The following is a description of a gene set: Mouse Gene Set: GOBP_SECONDARY_METABOLIC_PROCESS studied in species Mus musculus The chemical reactions and pathways resulting in many of the chemical changes of compounds that are not necessarily required for growth and maintenance of cells, and are often unique to a taxon. In multicellular organisms secondary metabolism is generally carried out in specific cell types, and may be useful for the organism as a whole. In unicellular organisms, secondary metabolism is often used for the production of antibiotics or for the utilization and acquisition of unusual nutrients., and this is the list of marker genes: Tyrp1, Cyp2a12, Mc1r (NCBI Gene Id 17199), Fmo2, Cyp1a2, a, Pon3, Rab38, Oca2, Prkce, Dct, Cyp1b1, Appl1, Ddt, Fmo1, Cyp1a1, Cyp2a5, Pam, Slc45a2, Cdh3, Ctns, Myo5a, As3mt, Ugt1a7c, Mfsd12, Akr1c6, Acmsd, Atp7a, Cbr4, Akr1c21, Cyp2a22, Slc7a11, Cpt1a, Akr1c18, Arl1, Slc24a5, Nfe2l2, Star, Gipc1, Rapgef2, Cyp2w1, N6amt1, Gsta3, Vhl, Th, Zeb2, Trpc1, Ugt1a8 (NCBI Gene Id 613123), Wnt5a, Cited1, Akr1b1, Akr1c13, Akr1a1 (NCBI Gene Id 80456), Abcc2, Tyr, Akr1c20, Akr1c12, Akr1c14, Cyp2a4, Bcl2, Pmel (NCBI Gene Id 20431), Opn3, Akr1c19, Bdh2, Akr1cl